Given this list of marker genes PLA2G4E (phospholipase A2 group IVE), NRGN, ZFYVE16, FCHSD2, MAPKAP1, OBSCN, ADAP2, KIF16B, ANXA8, OGT, GAB2, ARHGAP9, PHLDA3, COMMD1, DAPP1, PLEKHB2, PARD3, AKT1, IQGAP1, ARAP2, ARAP3, WASHC2C, ARAP1, CYTH3, GBF1, ZFYVE1, FUNDC2, FERMT2, HCN1, MYO1G, IQGAP2, DNM1, PIRT, JPH2, HIP1R, BTK, RACGAP1, MYO10, MYO1B, RAG2 (recombination activating 2), ADAP1, here is a description of the gene set: Human Gene Set: GOMF_PHOSPHATIDYLINOSITOL_3_4_5_TRISPHOSPHATE_BINDING studied in species Homo sapiens Binding to phosphatidylinositol-3,4,5-trisphosphate, a derivative of phosphatidylinositol in which the inositol ring is phosphorylated at the 3', 4' and 5' positions.